Given this list of marker genes WWTR1, PDGFRA, GNA11, MST1, FGFR1 (NCBI Gene Id 84151), NF2, LATS1, CDH16, PRKCH, PRKAB1, PRKAR1A, CTNNB1, CDH13, PLCB3, RHOA, PRKAR2B, FGFR4, CDH15, PRKCB, LEF1, IGF1R, PRKACG, CDH24, PLCB2, PRKAR1B, GNAI2, CSF1R, PRKAA2, STK3, PRKACA, EPHA2, TCF7L1, PRKAG1, PRKAG3, CDH6, TCF7, CDC42, FLT1, TEK, PLCB1 (phospholipase C beta 1), PRKCG, PRKAR2A, TEAD4, CDH10 (NCBI Gene Id 1008), PLCB4, CDH11, GNAI3, PRKAB2, PRKCZ, CDH19, SMAD2, NTRK1, CDH1, CDH3, EGFR, MTOR, NGFR, PRKD3, GNAS, CDH8, LATS2, KDR, PRKCI, GNAL, PRKAA1, FGFR2, MET, GNAQ, CDH17, FLT3, TEAD2, SMAD3, KIT, TEAD3, PRKCE, CDH22, CDH18, CDH2, YAP1, CDH4, PDGFRB, CDH9, PRKCA, NTRK2, FLT4 (NCBI Gene Id 7909), TCF7L2, CDH12, FGFR3, CDH5, PRKCQ, INSR, PRKACB, PRKCD, CDH20, CDH7, RAC1, PRKAG2, TEAD1, here is a description of the gene set: Hippo signaling regulation Human Gene Set: WP_HIPPO_SIGNALING_REGULATION species: Homo sapiens